The following is a description of a gene set: from publication Chen Y, Wang X (PMID 31504780) studied in species Mus musculus Mouse Gene Set: MIR_3103_3P Genes predicted to be targets of miRBase v22 microRNA mmu_miR_3103_3p in miRDB v6.0 with MirTarget v4 prediction scores > 80 (high confidence targets)., and this is the list of marker genes: Sh3glb1, Fhod3, Taf13, Vxn, Ankrd16, Ccdc47, Nudt3, Tnfaip2, Ppm1a, Aldh8a1, Atp2c1, Cisd2, Taf4, Slc1a3, Gnpnat1, Sytl5, Tnrc6b, Maea, Cab39l, Pm20d2, Nadk, Hmgn1, Sp100, Il11, Rgs7, Cphx1, Lhx2, Ccdc6, Slc49a4, Dut, St3gal4, B3gnt5, Fam117a, Pts, Ralb, Tmppe, Mbd4, Cmklr1, Pank3, Rnf145, Mtfp1, Zfx